The following is a description of a gene set: Human Gene Set: HP_ABNORMAL_SEXUAL_BEHAVIOR A deviation of sexual behaviors from the personal norms of the individual in the context of socially and culturally recognized patterns of human sexual behaviors. species: Homo sapiens Abnormal sexual behavior, and this is the list of marker genes: PTRHD1, MAPT, PSEN1, GNAS, GRN (NCBI Gene Id 2896), ATP7B (NCBI Gene Id 540), TRANK1, TDO2